Given this list of marker genes PVR, EPHB2, NPAS2, SFRP4, CTSB, ZNF132, PHLDB1, GPR19, LECT2, KCNA5, RYR3, PSD, SLC6A2, RREB1, FGF18, SLC4A4, ERCC4, C6, IL7 (interleukin 7), HTR1E (5-hydroxytryptamine receptor 1E), ZBTB14, FOSL1, PLXNA3, ATP8A2, RXRG, CMKLR2, EXOC4, FSHR, SULT4A1 (sulfotransferase family 4A member 1), RNF24, TENM4, LRP4, ATF2, POLR2K, GCM1, NTNG2, SIX6, GYS2, RBBP7 (RB binding protein 7, chromatin remodeling factor), MC5R, MAP2, DNAJC22, PCM1, LILRA4, DMD, CDH8, CRHR1 (corticotropin releasing hormone receptor 1), RSC1A1, KRT34, GRIK1, MAGEA8, GPR171, NR1I2, OR2B6, MINDY2, RAD51D, TANC2, LDB3, SLC17A1, CPB2, MON2, OR10H3, JRKL, FZD5, TBX19, F2RL1, CEP162, S100A5, ROR2, PDE6A, SOCS6, IL4, GABRB2, MASP2, MAP2K7, PLPPR4, HOXB7, APOBEC1, AKAP3, ABO, ADAMTSL3 (ADAMTS like 3), ZBTB40, GNG4, SLC6A4, POU6F2, AOC4P, SLC15A1, IFNA1 (NCBI Gene Id 89955), CALN1, PHOX2B, PTPRR, PART1, ZSCAN26, RB1CC1, COL19A1, MPZL1, LGI1, SPA17, CDH4, SOX11, NHEJ1, ITIH3, COLGALT2, PAX7, COX6A2, LILRA1, SERPINA4, REPS2, ABCB1, KLRC4, ATP4B, ANXA10, FGA, IFNA14, TACC2, ST8SIA1, SLC14A2, ITGBL1, JADE3 (jade family PHD finger 3), TNK1, HSD3B2, RGS7, GLRA3, SLC17A3, ZNF157, STAC, HCRTR2 (NCBI Gene Id 3062), GJB5, DNAJC16, SIM2, CLCN3, CDC73, CADM4, CA3, SRPK3, PSG1, POLR1HASP, VIP, SMYD3, NPFF, RORB, ZNF202, KRT2, TTTY1, CBLN1, TBXT, BRD4, IPO9, SUPT3H, COL8A1, TSHB, CAMK4, ULK2, GCA, SPRR2C, TRIO, SLC46A3, EDIL3, OR7A5, IFNW1, PHF10, PAX6, DGCR5, DRD1, PPM1E, MDM2, GPR15, CTRL, PDE4D, NEB, STARD5, TMEM26, HNF1A, HOXC11, NR3C2, MYT1, MAGEA9, AMMECR1, ADAM20, ATXN3, KPNA1, here is a description of the gene set: studied in species Homo sapiens Neighborhood of MAP2K7 Neighborhood of MAP2K7 mitogen-activated protein kinase kinase 7 in the MORF expression compendium Human Gene Set: MORF_MAP2K7